The following is a description of a gene set: Human Gene Set: GOBP_REGULATION_OF_SYNAPSE_STRUCTURE_OR_ACTIVITY species: Homo sapiens Any process that modulates the physical form or the activity of a synapse, the junction between a neuron and a target (neuron, muscle, or secretory cell)., and this is the list of marker genes: NRN1, NRXN2, ZNF804A, NEDD4L, CAMK1, AGO2, DMPK, PDXP, CDH2, FLRT1, ADGRB1, PAK3, DAB1, NRCAM, AMOT, SLITRK4, PPT1 (palmitoyl-protein thioesterase 1), EFNA1, SLC17A6, AMIGO2, STRN4 (striatin 4), CLSTN3, GHRL, CDK5R1, IGSF9, SIPA1L1, SARM1, NEGR1, RHOA, NECTIN3, SEMA4D, C1QL1, SLC17A8, DVL1, TREM2, ABHD17B, PRKCA, PDLIM5, NGEF, LRRN1, WNT7A, LRRN3, ARMCX5-GPRASP2, SYNGAP1, CDK5, RPS6KA5, IL10RA, CLN3, TUBB, SLC18A3, DOCK1, CRIPT, CHRNB2, LRFN2, SHANK3, SLITRK2, CBLN2, LZTS3, RELN, SRGAP2, LHFPL4, SEMA3F, CTTNBP2, SLC17A7, SLC30A1, CNTNAP1, DBN1, PGRMC1, CDC20, ZDHHC15, CTNNA2, DOCK10, S1PR2, SLITRK3, C1QL3, ADGRB3, NLGN2, RTN4R, OXT, LRFN5, GNA13, AKT1, NTRK2, ABL1, YWHAZ, FGF7, NEDD4, NF1, CRTAC1, CAPRIN1, UBE2M, ROBO2, LRP8, KIF1A, PTK2B, CUX2, NUMBL, DCTN1, ITGB1, SENP1, WNT5A, RAP2A, IGSF11, PRICKLE1, SRGAP2B, NAE1, TNF, ADNP, ARHGAP22, FYN, ARF6, GHSR, ADAM10, ADGRB2, ZDHHC8, LRFN4, MDGA1, NEURL1, EPHB2, STAU2, LRRC24, ARF4, CDC42, CYFIP1, CARMIL3 (capping protein regulator and myosin 1 linker 3), LINGO2, PDZD11, EEF2K, DOCK4, KLK8, WASL, SPARC, BAIAP2, NTRK1, DKK1, NEDD8, EGLN1, NTNG2, NEDD9, PAFAH1B1, PPFIA2, FZD1, SLC7A11, SNX27, RAC3, SIX1, CDKL5, SLITRK1, VCP, CYFIP2, CAMKV, NCKIPSD, ARC, NTRK3, LINGO4, KIF5B, APP, CACNA2D3, IL1RAP, CRMP1, MRTFB, MYCBP2, WNT3A, CHMP2B, LATS1, CFL1, CLSTN1, THBS2, ICAM5, FGFR1, DHX36, SEMA4C, PTPRO, ARHGAP44, PUM2, LIN7A, EPHA7, SETD5, SYNDIG1, GPRASP3, LRTM2, PCDH8, MARK1, TANC2, CHD4, NLGN3, TANC1, CC2D1A, TUBA1A, PRMT8, EPHB1, FGF22, ELMO1, PSEN1, IL10, VSTM5, ANAPC2, RHOB, SRPX2, CBLN1, ASIC2, VLDLR, GRID2, GRID1, KCNK13, NLGN4X, ABI3 (NCBI Gene Id 51225), ARHGAP33, PTPN13, ITPKA, DRD2, NEFL, MEF2C (NCBI Gene Id 4208), ROCK1, RAB17, AGAP1, EPHA4, NLGN1, BDNF, LRRTM2, SRCIN1, DLGAP4, NEUROD2, CASKIN1, ABHD17C, DTNBP1, DAB2IP, PTPRS, SPARCL1 (SPARC like 1), LRFN1, ZMYND8, DLG5, EIF4G1, SNCA, LRRK2, LRFN3, SLITRK5, AMIGO3, ABI2, SYBU, TRIM47, COLQ, IQSEC2, IL1RAPL2, CDH8, FCGR2B, MIR431, PLPPR4, GPR158, OGT, UBE3B, SIX4, MUSK, INS, SEMA4A, CLSTN2, PRNP, LIN7B, SLC12A5, LIN7C, MAP1B, FARP1, DISC1, ABHD17A, EFNA5, VANGL2 (VANGL planar cell polarity protein 2), SLIT1, IL1RAPL1, SRGAP2C, NTN1, ITSN1, AGRN, NRXN1, MIR30B, ARHGAP12, HTR4, APOE, SEMA7A, TPBG, GPM6A, AMIGO1, LZTS1, CTNNB1, PTPN1, SIGMAR1, DAG1, PPP1R9B, LILRB2, MAPK14, RTN4, CAMK2B, FLRT3, NECTIN1, GRIN2B, TLR2, CAPRIN2, FRMPD4, NFATC4, PTPRD, ST8SIA2, LRRTM1, C1QL2, LRRC4B, LRRTM3, EPHB3, ASIC1, NRP2, PLXNC1, HOMER1, RHOG, FLRT2, SLITRK6, LRP4, ARHGEF15, ZDHHC17, RAC1, ETV5, VPS35, GPC4